The following is a description of a gene set: from publication Chen Y, Wang X (PMID 31504780) Mouse Gene Set: MIR_326_5P species: Mus musculus Genes predicted to be targets of miRBase v22 microRNA mmu_miR_326_5p in miRDB v6.0 with MirTarget v4 prediction scores > 80 (high confidence targets)., and this is the list of marker genes: Acot11, Eeig1, Ptprj, Hapln4, Mark2, Slc19a1, Shisal1, Nkx2-2, Cidec, Tmem141, Adarb1 (adenosine deaminase, RNA-specific, B1), Pgpep1, Arid1b, Ifitm1, 2010003K11Rik (RIKEN cDNA 2010003K11 gene), Prkar2a, Nradd, Mfn2, Klhdc3, Tsc1, Bgn, Slc25a42, 4921536K21Rik, Dnaaf9, Hmga1, Celf4, Trak1, Nol10, Mapre1, Ctdsp2, Trabd2b, Ndor1, Vps41, Mtnr1a, Gdnf, Nectin1 (nectin cell adhesion molecule 1), Zc4h2, Zfp593, Trh, Hmga1b, Col18a1, Plcb1, Plppr2, Itpkb, Mecp2, Carhsp1, Maf, Glis2, Vipr2, Dcakd, Tmem132e, Ints11, Tulp3, Spock2, Anpep, Cftr, Camk2a, Sgcd, Cdc42ep1, Metap2, Foxd2, Fbxo41, Nr5a1, Krt73, Fcgr4, Il22ra1, Chst15, Asxl3, Ly6e, Syndig1l, Dmbx1, Dtx3, Rtl5 (retrotransposon Gag like 5), Sh3tc2, Snai3, Sp7, Crtc1, Ap1b1, Ctsd, Osgin1, Ppp1ca, Scn2b, Fndc5, Ttyh3, Scn3a, Mmp24, Atxn7l3, Tns4, Rph3a (NCBI Gene Id 70216), Adamts4, Map3k11, Pfn2, Prpf4, Tanc2, Kcna1, Il2rb, Ccdc97, 4933434E20Rik, Tgfbrap1, Pcsk4, Aif1l, Traf3, Trim47, Nsl1, Maob (monoamine oxidase B), Flnc (filamin C, gamma), Dgkd, Zmynd10, Elmo1, Lhfpl4, Rnf44, Yipf2, Zfp609, Ssu2, Psenen, Phb1, Sh3kbp1, Luzp1, Tada2b, Cplx2, Snph, Nat8l (NCBI Gene Id 68762), Sdc3, Nsg1, Gnpda1, Psg29, Rerg, Abcg4